Given this list of marker genes AFF3, TMEM132D, APOD, TFPI, AGTR1, SERTAD4BP, CPB1, GALR1, THSD7A, STK33, CRYBA2, RAMP1, FMN2, PCSK1 (proprotein convertase subtilisin/kexin type 1), PAX4, ADCY1, UCN3, ATP6V1C2, MAPK8IP2, TTC23L, PTPRN, PSCA, SETBP1, SLC5A8, CACNA1A, CNIH2, BAIAP3, PNPLA3, SCRN1, KCNH2, ELAVL4, CEP126, RIMS2, RIMBP2, GPRASP1, KIF5C, CTNND2, MAPK8IP1, CAMK2N2, PRAF2, RFX6, TMEM198, CCDC74A, CADPS, APBB1, ETV1, MAP9, SYN1, SLC26A7, KL, KCNJ3, CACNA2D1, RIIAD1, KCNH8, SLC15A1 (NCBI Gene Id 6564), PTK7, TUBA1A, SAMD3, OGDHL, ALPK3, SCGN, FGFR1, IGFBP3, PAM, FRY, TMEM63C, PDX1, TSPAN5, CCDC181, MAPRE3, PCLO, CPE, LCN15, ENKD1, NBEA, SMARCA1, F5, CAMK2B, GPR173, STXBP5L, MLXIPL, CASTOR3P, BMPR1B, LINC01014, COL8A2, ACP3, STMN3, ADAMTSL2, FBXL16, MAFA (MAF bZIP transcription factor A), SMOC1, MARCHF4, FAR2P2, GLYATL3, FRMD6, PLCXD3 (phosphatidylinositol specific phospholipase C X domain containing 3), NKX2-2, LINC02712, SLC25A27, SOX12, NCALD, TAFA5, MTCL1, CDH22, OSCP1, CBLN2, DUSP26, DUSP4, KCNK3, CXXC4, SLC16A12, MAP1B, RASA4, BMERB1, MAP2, CDK5R2, KIF1A, KCNMB2, DNAI3, BEX1 (brain expressed X-linked 1), SLC26A4-AS1, SYP, COL5A2, LINC01571, MSI1, PEG10, SNAP25, FFAR2, C7, GFRA3, ASPA, CHRNB2, PRPH, GOLGA7B, FBLL1, KCNH6, CFC1, SYNPR, LINC01725, PDE2A, KLRC2, CBX6, OR51E2, ITFG2-AS1, ARNT2, SCG2, HOPX, ALKAL1, CHGB, ZNF460, SLAIN1, GNAZ, RNF183, ZP2, MARK1, C2CD4B, EFCC1, STMN2 (NCBI Gene Id 11075), CCDC74B, TNNC1, VGF, PLXND1, TM7SF2, CEP170, CFAP300, MS4A8, ST18, C1orf127, NINL, GPRIN1, CPLX2, PALMD, NFASC, AP3B2, REG4, CDHR3, SPOCK1, SSTR5-AS1 (NCBI Gene Id 146336), FEV, TDRP, C19orf44, TUBB2B, SLC7A2, ZFR2, TPH1, PCSK1N, RTN1 (reticulon 1), KRT40, SCG3, ARC, ARHGEF38-IT1, DIRAS3, LMX1A, NRP1, MATCAP2, ARVCF, HDAC9, SLC38A11, CALML3-AS1, LINC02593, SEZ6, CACNA1D, APLP1, RUNDC3A, CES1, PCBP4, AOAH, BCAS4, PENK-AS1, TTR, KIF26A, NCKAP5, MAP6, AMIGO2, RAPGEF4, SPART, VAT1L, SLC18A1, TAMALIN, MAP7D2, FGFBP3, ENPP2, SDK2, PAX6, SLC16A2, TCEAL3, WASF3, BMPER, ABTB3, LRRC36, CDKN2A, SYT4 (synaptotagmin 4), CCDC40, DZIP3, VWA5B2, RGS4, KIAA0319, KCNC1, MAMSTR, BNIP3 (NCBI Gene Id 664), LARP6, TTC41P, INSL5, SYT5, TAF6L, DRICH1, STX1A, PF4V1, SPHK1, SPRED3, MTCL3, PAPPA2, RFX3, PPFIA2, FTX, GDF11, PCDH9, RAI2, GJA4, COL2A1, SCN3A, FSTL4, NEUROD1, NAB2, FAP, MTURN, PITX3, ENSG00000286190 (novel protein), ABAT, NPY1R, SCG5, ISL1-DT, GNG2, SV2C, SCAMP5, CASR, INSM1, CBLN1 (NCBI Gene Id 869), GNAO1 (NCBI Gene Id 2775), SEMA3G, GLIS3, NEFL, B3GAT1, CXCL6, ISYNA1, CEP15, NOL4, MMP2, SLC29A4, GULP1, ANK2, QPCT, JAZF1, TMOD1, UNC13A, DNAI7, TGM3, LINC00670, MCOLN3, SYT1, SCT, VNN3P, RAB3C, AKAP6, AMER3, TRAM1L1, RGS9, SPTBN4, PGAM2, GSG1, RANBP3-DT, PRKD1, here is a description of the gene set: species: Homo sapiens from publication Gao S, Yan L, Wang R, Li J, Yong J, Zhou X, Wei Y, Wu X, Wang X, Fan X, Yan J, Zhi X, Gao Y, Guo H, Jin X, Wang W, Mao Y, Wang F, Wen L, Fu W, Ge H, Qiao J, Tang F (PMID 29802404) Human Gene Set: GAO_LARGE_INTESTINE_ADULT_CA_ENTEROENDOCRINE_CELLS